The following is a description of a gene set: Mouse Gene Set: GOCC_GBAF_COMPLEX studied in species Mus musculus A SWI/SNF subcomplex that incorporates two mutually exclusive paralogs, GLTSCR1 (glioma tumor suppressor candidate region gene 1) or GLTSCR1L (GLTSCR1-like), BRD9 (bromodomain-containing 9) and the BAF subunits BAF155, BAF60, SS18, BAF53a, and BRG1/BRM., and this is the list of marker genes: Smarcd1, Actl6a, Smarca4, Bcl7a, Ss18 (NCBI Gene Id 268996), Actl6b, Brd9, Bcl7b, Actb, Bcl7c, Bicral, Smarcc1, Smarca2, Bicra